The following is a description of a gene set: Mouse Gene Set: REACTOME_NERVOUS_SYSTEM_DEVELOPMENT Nervous system development studied in species Mus musculus, and this is the list of marker genes: Vav3, Col2a1, Adgrg6, Hras, Pak1, Msn, Cxcl12, Uba52, Creb1, Dnm1, Ephb6, Arpc3, Tuba1a, Efna5, Met, Ntn4, Arpc1b, Efna1, Sema7a, Epha10, Sptbn1 (NCBI Gene Id 268394), Irs2, Sptbn2, Tyrobp, Rac1, Mapk3, Git1, Ap2m1, Plxnb3, Pik3r2, Dnm2, Dpysl5, Trem2, Psen1, Col3a1, Arpc2, Pip5k1c, Ezr, Efnb1, Itga5, Col6a5, Rhoc, Efna3, Col4a1, Prkacb, Fes, Csnk2b, Ptpra, Efna2, Arhgef28, Efnb2, Sptbn4, St8sia4, Vav2, Sh3gl2, Rhoa, Reln, Plxnc1, Sos1, Col9a3, Abl2, Epha6, Kalrn, Rap1gap, Tubb3, Nck2, Tuba4a, Ncstn, Ephb2, Gdnf, Tubb4b, Gsk3b (NCBI Gene Id 98033), Dok1, Rhob, Sema3e, Lypla2, Usp33, Rras, Plxna2, Dok4, Yes1, Rdx, Ap2b1, Kif4, Sptan1, Tubb6, Col4a2, Aph1a, Rock2, Ptprc, Vasp, Ngef, Actb, Dok2, Pik3cd, Mmp2, Pik3cb, Gab1, Arhgef12, Numb, Abl1, Nfasc, Clta, Slit3, Grb7, Dnm3, Myo9b, Enah, Plcg1, Shc1, Ephb3, Col4a3, Epha7, Dscaml1, Sdcbp, Gfra1, Epha4, Sptbn5, Arpc4 (actin related protein 2/3 complex, subunit 4), Cdk5, Itga2b, Kras, Epha8, Tubb2b, Col4a4, Col5a2, Map2k2, Plxnd1, Csnk2a2, Col6a3, Psenen, Vldlr, Pak3, Actg1, Pik3r3, Tuba3b, Tubb2a, Pdlim7, Arhgap35, Rps27a (ribosomal protein S27A), Src, Dpysl4, Ptpn11, Rasa1, Sema4d, Grb10, Limk1, Rock1, Itga9, Ephb1, Slit2, Pak2, Itsn1, Tubb4a (NCBI Gene Id 22153), Ubb, Tln1, Crmp1, Col5a1, Ap2a1, Col6a1, Unc5a, Itgb3, Hsp90aa1, Col6a2, Shc3, Tuba8, Dok6, Plxna4, Mmp9, Col4a5, Hsp90ab1, Nrtn, Prkaca, Col9a2, Tubal3, Mapk7, St8sia2, Prkcq, Gfra2, Evl, Itgb1, Dag1, Ubc, Rps6ka5, Cdk5r1, Frs2 (NCBI Gene Id 327826), Mapk1 (mitogen-activated protein kinase 1), Dpysl3, Efnb3, Pfn2, Cdc42, Plxna1, Sh3kbp1, Ranbp9, Shank3, Arpc1a, Gpc1, Dpysl2, Uba52rt, Cltc, Epha2, Erbb2, Dok5, Trio (NCBI Gene Id 77730), Col6a6, Plxna3, Actr2, Egfr, Arpc5, Gap43, Nck1, Rnd1, Spta1, Ap2s1, Arhgef7, Cxcr4, Pspn (NCBI Gene Id 19197), Aph1b, Fyn (Fyn proto-oncogene), Grb2, Pik3ca, Cd72, Col5a3, Sema6d, Epha1, Dab1, Tubb1, Ephb4, Dscam, Efna4, Tuba1c, Dock1, Pik3r1, Pfn1, Arhgef11, Ank1, Sema5a, Sdc2, Artn, Lyn, Col9a1, Gfra3, Itgav, Grin1, Nrp1, Ret, Ap2a2, Ptk2, Tuba1b, Dcc, Sptb, Fgfr1, Farp2, Gfra4, Csnk2a1, Actr3, Tuba3a, Sema4a, Plxnb1 (NCBI Gene Id 70220), Map2k1 (mitogen-activated protein kinase kinase 1)